The following is a description of a gene set: species: Homo sapiens Human Gene Set: GOBP_UNSATURATED_FATTY_ACID_METABOLIC_PROCESS The chemical reactions and pathways involving an unsaturated fatty acid, any fatty acid containing one or more double bonds between carbon atoms., and this is the list of marker genes: SCP2, PTGR2, FADS2, MIF, ABCD2, MIR766, ALOXE3, CYP2C19, AVP, FADS1, TNFRSF1A, PTGR1, PLA2G4A, MGST3, CYP2U1, CYP1A2, PLA2G3, ACOX1, PTGIS, EDN2, CYP2B6, ELOVL7, ELOVL6, PLAA, HSD17B4, ABHD12, TMEM135, ABHD6, CYP4A22, DEGS1, HPGD, CYP4A11, TBXAS1, ATP6V1B1, PTGS1, PLA2G10, FADS2B, PIBF1, PRXL2B, ALOX15, PLA2G4C, CYP1A1, ACSL4, MIR204, CYP2C18, CYP4F2, PTGES, CD74, GSTA1, CYP4F12 (NCBI Gene Id 66002), COMT, GPX1, AVPR1A, PTGES3, AKR1C3, CYP2A13, GSTM2, IL1B, SCD, DAGLB (NCBI Gene Id 221955), EDN1, CYP2J2, ACSL1, ACAA1, ALOX12, AKR1B1, PTGDS, GPX4, ALOX12B, EHHADH, AKR1C1, ELOVL5, GSTM1, CYP2C8, FAAH, CYP2A7 (NCBI Gene Id 1549), PLA2G2F, ELOVL3, AKR1C4, CYP4F3, EPHX1, PNPLA8, CES2, CTHRC1, AWAT1, ELOVL1, DAGLA, PTGES2, FAAH2, SCD5, MIR132, CYP2D6, ABCD1, CYP4F11, CYP1B1, AKR1C2, CYP4F8, CYP2A6, ALOX15B, HPGDS, FADS3, PLA2G4F, SIRT1, CYP2E1, ACOT8, ALOX5, MGLL, ELOVL4, GSTP1, CBR1, PTGS2 (NCBI Gene Id 5743), DECR2, CYP4Z1, FABP5 (fatty acid binding protein 5), CYP2C9, CYP2S1, ELOVL2, PLA2G4B, CYP2F1